Given this list of marker genes LPCAT3, RNF2, PDPK1, MARK4 (microtubule affinity regulating kinase 4), STK40, DCAF1, PLEKHA6, ZNF512B, VAPB, TNPO1, BARX1, PDGFRB, PRDM16, BRD2, CPSF7, HMG20B, PTPN21, BRPF1, CALU, DNAJC24, MAGEB6 (NCBI Gene Id 158809), DPH2, HEXIM1, DBN1, RAD23B, ZNF316, KCNQ4, CSF2RA, PKP1, ZSWIM8, MPI, DYRK1B, ARID3B, GPATCH2L, MLEC, PEF1, AHSA1, DTNA, KCND3, AGPAT3, SUDS3, TBX6, SDC3, TNFSF10, TMEM79, RNF26, FYCO1, IVNS1ABP, SNPH, EPHB3, NCAPH2, SGPP2, KAT2A, CBX1, CAPN5, P2RY4, ONECUT2, RUSC2, WIZ (WIZ zinc finger), PTGER2, here is a description of the gene set: from publication Chen Y, Wang X (PMID 31504780) studied in species Homo sapiens Genes predicted to be targets of miRBase v22 microRNA hsa-miR-874-5p in miRDB v6.0 with MirTarget v4 prediction scores > 80 (high confidence targets). Human Gene Set: MIR874_5P